Given this list of marker genes LTBP3, ASXL1, FOXA1, STRA6, GATA6, FGF10, FOSL2, NKX2-1, CREB1, here is a description of the gene set: The biological process whose specific outcome is the progression of a lung saccule from an initial condition to its mature state. The lung saccule is the primitive gas exchange portion of the lung composed of type I and type II cells. species: Homo sapiens Human Gene Set: GOBP_LUNG_SACCULE_DEVELOPMENT